Given this list of marker genes GCSAML, RETREG1, ODF2L, FAT4, PLEKHA8, FGF12, LRP8 (LDL receptor related protein 8), SPTY2D1, MTM1, CCDC125, USP27X, PCDHB9, PIK3C2A, DICER1, HIPK2, NT5C2, PCDH15, RORB, LIPA, PYROXD1, LYRM7, UQCRQ, WDR64, ITGA4, RBMS3, MED14, PRDM5, TMEM70, CRYAB, GLCE (NCBI Gene Id 90998), SAMD8, PPP1R14D, SOX21, PKP2, SMAD6, ONECUT2, NRP2, SRP9, ZNF398, ADAMTS3, HSPE1-MOB4 (NCBI Gene Id 100529241), MLLT3 (MLLT3 super elongation complex subunit), DSG1, DPY19L3, CENPQ, ZNF449, CYYR1, BCL11B, CDC37L1, COBLL1, PAFAH1B2, ICOS, CYB5B, KIAA0586, MYH11, NIPBL, PRKCQ, VEGFA, ATP9A, MSRB3, TNFSF13B, CEP57L1 (centrosomal protein 57 like 1), KCNV1, COL19A1, KIAA1549L, MOB1A (MOB kinase activator 1A), KIAA1328, SEZ6L, SLC36A4, SLC38A6, GRID1, CREBL2, HACD1, SHOX2, SMAP2, BAAT, VIP, ARHGEF9, CTSO, PRKAR2B, LSM5, FBXO4, FNTA, CTNNA2, DTD2, MOB4, PPM1A, RNF217, TAFA1, LDB2, CA12, SAXO2, MRAP2, HOOK3, MAGI3, RUFY2, ZNF569, MEF2A, ABCD4, LIMS1, CPEB3, GLIPR1L2, DPYD, WNT5A, GRB2, PPP3R1, TCTN1, HIF1A, FUT9, ZBTB20, FRMD4B, PCSK2, FSTL5, STAC, PFN2, EPM2A, DCAF1, HTR1B (5-hydroxytryptamine receptor 1B), DKK2, SIX3, CR1, TP63, TOX3, CPED1, SPDYA, ZBTB41, TNFRSF19 (TNF receptor superfamily member 19), BAG2, SLC24A2, KCND2, BRIX1, PHLDB2 (pleckstrin homology like domain family B member 2), ABHD13, TMED5, TMEM212, TRPC6, SOCS2 (NCBI Gene Id 8835), ZNF25, ANO2, TACC2, CIT, SLC35F2, DCTN6, SRP72, TENM3, TBC1D1, LPL, ZNF559, C2orf88, EPHB1, TBCK, QSER1, SCML1, USP15, ULBP1, GLIS1, C9, KCTD8, UPP1, CNOT6L, TGFB2, SCRN3, ARID1B, ZNF365 (NCBI Gene Id 89878), JAZF1, MEOX2, ZNF331, PAPPA, USP30, FZD8, MAP7, MAP3K2, AHCYL2, MBNL3, LPP, LDLRAD4, PELI1, AMDHD1, here is a description of the gene set: from publication Chen Y, Wang X (PMID 31504780) Genes predicted to be targets of miRBase v22 microRNA hsa-miR-578 in miRDB v6.0 with MirTarget v4 prediction scores > 80 (high confidence targets). Human Gene Set: MIR578 species: Homo sapiens